The following is a description of a gene set: Neighborhood of RBBP6 retinoblastoma binding protein 6 in the GNF2 expression compendium Human Gene Set: GNF2_RBBP6 species: Homo sapiens Neighborhood of RBBP6, and this is the list of marker genes: WAPL (NCBI Gene Id 23063), RBM15, HDAC1, MRPS31, HSPA14, EIF4B, SMARCA5, HNRNPDL, UBXN4, RPL35A, NOL8, FIP1L1, RBBP6, RBMX, RBM25, AIMP1, PIKFYVE, PAPOLA, SCAF11, SRP72, GTF3A, USP16, THUMPD1, CCDC59, THOC2, UBP1 (upstream binding protein 1), RBM34, PTMA, BPTF, NSA2, PMPCB, SRSF7 (serine and arginine rich splicing factor 7), CNOT7, NGLY1, DCLRE1C, DDX50, NOL11, CEBPZ, EIF3D, NACA, FUS, INTS8, EIF3E, DDX47, HNRNPA1, OFD1 (NCBI Gene Id 8481), RPS7, BTAF1 (B-TFIID TATA-box binding protein associated factor 1, NCBI Gene Id 9044), FBL, HNRNPH3, TRAPPC8, SRSF2, TARDBP, RPL22, RSRC2, EXOSC8, PABPN1, RBM39, RPL5, CDV3, ESF1, TENT4A, DDX18, SUZ12, RNF138, ZNF146, CDK5RAP1, PNN, RPS23, PDS5A